The following is a description of a gene set: Human Gene Set: MIR4769_5P from publication Chen Y, Wang X (PMID 31504780) species: Homo sapiens Genes predicted to be targets of miRBase v22 microRNA hsa-miR-4769-5p in miRDB v6.0 with MirTarget v4 prediction scores > 80 (high confidence targets)., and this is the list of marker genes: RNF123, KIF13A, TRDMT1, FBXL7, SLC25A23, USP48, KCNB1, MARCHF7, PIK3AP1, ABI2, POU5F1, AFF2, ACAN, MYO19, ASPH, ELAVL1, UBE2H, ROBO2, MMP25, DBT, RELN, TMEM221, TMEM41B, PDZD2, FAM131B, PAXBP1, ANKRD49, AP1G1 (NCBI Gene Id 164), ERMN, COL19A1, PUS7L, HSF2BP, FBXO36, MEF2C, DNAJA2, ENSG00000255537, ALDH6A1, RAG2, PARP15, TSHZ3, NXPE1, POU5F1B